Given this list of marker genes HLA-DQA1, MTTP, ALDH18A1, UROS, MST1, SBDS, OCRL, FARSB, SEMA4D, PKHD1, CTNS, FGF23, GALNT2, ACOX2, ELN (elastin), DZIP1L, RPS10, MMP1, SLC51B, PTH1R, FOCAD, FBLN5, EFL1, COL7A1, SLC10A1, SLC37A4, DNAJC21, HLA-DQB1, RPL11, GALT, GATA1, GPR35, TCF4, here is a description of the gene set: Decreased circulating vitamin D concentration studied in species Homo sapiens Human Gene Set: HP_DECREASED_CIRCULATING_VITAMIN_D_CONCENTRATION The concentration of vitamin D in the blood circulation is below the lower limit of normal.